Given this list of marker genes AKR1C3, ECSCR, CD248, RGCC, FASLG, F3, PTPN1, MIR375, MIR125A, PRKCI, CD40, ANO6, FOXO3, PLCG1, GPER1, CD40LG, ITGA4, MIR132, MIR15A, PDCD4, CCL2, MIR101-1, NGFR (nerve growth factor receptor), MIR24-1, TGFB1, CD160 (NCBI Gene Id 11126), XBP1, HLA-G (NCBI Gene Id 3135), THBS1, here is a description of the gene set: Human Gene Set: GOBP_POSITIVE_REGULATION_OF_ENDOTHELIAL_CELL_APOPTOTIC_PROCESS species: Homo sapiens Any process that activates or increases the frequency, rate or extent of endothelial cell apoptotic process.